Given this list of marker genes Pgrmc1, Ramp3, Clip3, Arhgef16, Pkp1, Dlg1, Acsl3, Cnpy4, Dpp10, Ephb2, Lgals3, Pdpk1 (NCBI Gene Id 18607), Cib1, Vil1, Stac2, Rhog, Dpp6, Kif5b, Myo5b, Stx3, Cnst, Kcnj11, Prkci, Actr3, Nkd2, Prnp, Rer1, Rack1, Sqstm1, Trem2, Akap5, Myo5a, Atp2c1, Rangrf (NCBI Gene Id 80408), Grip1, Stac, Commd1, Stac3, Ezr, Itga3, Nrxn1, Sptbn1, Epha2, Sorbs1, Gper1, Wnk3, Egfr, Akt1, Ptpn9 (protein tyrosine phosphatase, non-receptor type 9), Pls1, Agr2, Tnf (tumor necrosis factor), Atp2b4, Cln3, Rab11fip2, Ppp1r9b, Lrp1, Wnt3a, Itgb1, Rab11a, Arf6, Zdhhc5, Epha3, Stx4a, Zdhhc2, here is a description of the gene set: Any process that activates or increases the frequency, rate or extent of protein localization to plasma membrane. species: Mus musculus Mouse Gene Set: GOBP_POSITIVE_REGULATION_OF_PROTEIN_LOCALIZATION_TO_PLASMA_MEMBRANE